The following is a description of a gene set: Excessive or pathological tendency to save and collect possessions. Human Gene Set: HP_COLLECTIONISM Collectionism studied in species Homo sapiens, and this is the list of marker genes: TMEM106B, CHMP2B, SLC6A4, MAPT, VCP, SQSTM1, HTR2A, PSEN1 (presenilin 1), TREM2, GRN